Given this list of marker genes KDM2B, BDKRB1, NEXN, VSX2, PTPN6, IRX1, MUC6, NPC2, EPPK1, RTF1, DNASE1L1, DUSP5, ITPRIPL2, RXRG, ZNF146, FARP2, PGLYRP4, SPATA13, RBMX2, KCMF1, NAPA, GPBAR1, STAC2, TIPRL, PRR14L, SERPINA13P, AKAP7, BANF2, here is a description of the gene set: from publication Franco LM, Bucasas KL, Wells JM, Niño D, Wang X, Zapata GE, Arden N, Renwick A, Yu P, Quarles JM, Bray MS, Couch RB, Belmont JW, Shaw CA (PMID 23878721) Genes negatively correlated with antibody response in blood in adults (18-40) after exposure to Sanofi Pasteur, SA, Inactivated influenza vaccine, time point 14D Identification of the host genetic factors that contribute to variation in vaccine responsiveness may uncover important mechanisms affecting vaccine efficacy. We carried out an integrative, longitudinal study combining genetic, transcriptional, and immunologic data in humans given seasonal influenza vaccine. We identified genes exhibiting a transcriptional response to vaccination, significant genotype effects on gene expression, and correlation between the transcriptional and antibody responses. The results show that variation at the level of genes involved in membrane trafficking and antigen processing significantly influences the human response to influenza vaccination. More broadly, we demonstrate that an integrative study design is an efficient alternative to existing methods for the identification of genes involved in complex traits. DOI:http://dx.doi.org/10.7554/eLife.00299.001. studied in species Homo sapiens Human Gene Set: FRANCO_BLOOD_SANOFI_PASTEUR_SA_INACTIVATED_INFLUENZA_VACCINE_CORRELATED_WITH_ANTIBODY_RESPONSE_AGE_18_40YO_14DY_NEGATIVE